The following is a description of a gene set: Any process that stops, prevents, or reduces the frequency, rate or extent of the chemical reactions and pathways resulting in the formation of glycogen. Mouse Gene Set: GOBP_NEGATIVE_REGULATION_OF_GLYCOGEN_BIOSYNTHETIC_PROCESS studied in species Mus musculus, and this is the list of marker genes: Inpp5k, Pask, Enpp1, 1810024B03Rik, Gsk3b, Gfpt1, Grb10, Prkag3